The following is a description of a gene set: species: Homo sapiens part of: Diseases of Telomere Maintenance Alternative lengthening of telomeres (ALT) is a homologous recombination repair-directed telomere synthesis that takes place in 5-15% of tumors. ALT positive tumors often harbor loss-of-function mutations in ATRX (Alpha thalassemia mental retardation X-linked) or, more rarely, DAXX (Death domain-associated protein 6) chromatin remodeling factors, which may act to inhibit DNA recombination at telomere ends. The nuclear receptor complex NuRD-ZNF827 contributes to the recruitment of homologous recombination (HR) machinery to telomeres. ALT is most prevalent in subsets of sarcomas, including osteosarcomas and some soft tissue sarcomas, brain cancers and neuroblastomas. For review, please refer to Nabetani and Ishikawa 2011, Pickett and Reddel 2015, Verma and Greenberg 2016, Amorim et al. 2016, Sommer and Royle 2020, Zhang and Zou 2020. Reactome Pathway: Alternative Lengthening of Telomeres (ALT), and this is the list of marker genes: ATRX, DAXX